Given this list of marker genes PTPA, VCAN (versican), SLC39A10, CD33, IGFBP3, here is a description of the gene set: Binds to and increases the activity of a phosphotyrosine phosphatase, an enzyme which catalyzes of the removal of a phosphate group from a tyrosyl phenolic group of a protein. species: Homo sapiens Human Gene Set: GOMF_PROTEIN_TYROSINE_PHOSPHATASE_ACTIVATOR_ACTIVITY